Given this list of marker genes Ssbp1, Ereg, Ttf1, Dhx9, Il6, Jun, Rad17, Id3, Lig3, Ruvbl2, Stn1 (NCBI Gene Id 69648), Yy1, Mas1, Met, Cdt1, Rbbp6, Ino80c, Lpin1, Gmnn, Dach1, Jade1, Atr, Wapl, Mapk8, Kat7, Hras, Ino80b, Zbtb38, Actr8, Dynll1, Dna2, Fgfr1, Timeless, Atad5, Gmnc, Cdk2, Fbxo5, Hcrt, Trp53, Atg7, Ruvbl1, Egfr, Zmpste24, E2f8, Cst3, Obi1, Atrx, Esco1, Gli1, Dbf4, Gtpbp4, Wrnip1, Ccna2, Rac1, Map2k4, Orc3, Dscc1, Smarca5, Brpf3, Atf1, Jade2 (jade family PHD finger 2), Pcna, Pole3, Tnfaip1, Inppl1, Gli2, Ino80d, Endog, Terf1, E2f7, Baz1a, Mapk15, Ehmt2, Npm2, Nuggc, Mtnap1, Pds5a, Jade3, Uchl5, Ankrd17, Cacybp, Aicda, Orc5, Ino80e, Cdc7, Npm1 (nucleophosmin 1), Cdk1, Meaf6, Smc3, Tfpt, Mcrs1, Kctd13, Ticrr, Faf1, Nucks1, Nfrkb, Ilkap, Actl6a, Chrac1, Ager, Mcidas, Usp37, Ucn, Ciz1, Ing5, Tipin, Ctc1 (NCBI Gene Id 68964), Esco2 (establishment of sister chromatid cohesion N-acetyltransferase 2), Wiz, Tspyl2, Ino80, Pdgfb, Mettl4, Senp2, Enpp7, Blm, Actr5, Cdc42, here is a description of the gene set: species: Mus musculus Any process that modulates the frequency, rate or extent of DNA replication. Mouse Gene Set: GOBP_REGULATION_OF_DNA_REPLICATION